The following is a description of a gene set: The process whose specific outcome is the progression of a nail over time, from its formation to the mature structure. A nail is a horn-like envelope covering the outer end of a finger or toe, and consists of the nail plate, the nail matrix and the nail bed below it, and the grooves surrounding it. species: Mus musculus Mouse Gene Set: GOBP_NAIL_DEVELOPMENT, and this is the list of marker genes: Msx1, Itga6, Prkab1, Rspo4, Prickle1, Fzd6, Foxn1, Itgb4, Hoxc13 (NCBI Gene Id 223923), Msx2